The following is a description of a gene set: studied in species Homo sapiens An intracellular signaling cassette characterized by the NIK-dependent processing and activation of NF-kappaB. Begins with activation of the NF-kappaB-inducing kinase (NIK), which in turn phosphorylates and activates IkappaB kinase alpha (IKKalpha). IKKalpha phosphorylates the NF-kappa B2 protein (p100) leading to p100 processing and release of an active NF-kappaB (p52). The non-canonical NF-kappaB signaling pathway is generally activated by ligands of the TNF receptor superfamily, including lymphotoxin beta (LTB), CD40, OX40, RANK, TWEAK and B cell-activating factor (BAFF). Human Gene Set: GOBP_NON_CANONICAL_NF_KAPPAB_SIGNAL_TRANSDUCTION, and this is the list of marker genes: LGALS9, RIPK3, TRIM56, MKRN2, ZFP91, AMFR, CALR, CARD10, PHB2, SPI1, EZR, TAB2, RHOA, NLRC3, LIME1 (NCBI Gene Id 54923), MIR223, TCIM, BIRC3, REL, MIR149, COPS8, ZC3H12A, RELB, NFKB1, RELA, IL1B, MIR15B, NLRP12, NMI, IL23A, RBCK1, C1QTNF3, MIR9-1, AKIP1, PPM1A, RPS3, SASH1, BTRC, LAPTM5, HDAC7, TLR6 (toll like receptor 6), IL18R1, PTPN22, TNFSF11, NDUFC2 (NCBI Gene Id 4718), PYDC2, NOD2, BMP7, IFI35, LITAF, TREM2, NOD1, RIPK1, MIR27A, APP, IL18, TRIM6, HAVCR2, MIR508, LRRC19, TLR3, PYCARD, BIRC2, TAB3, TNFRSF11A, PTP4A3, TNFRSF10A, PRDX1, TRIM55, RC3H2, CARD14, AGO1, TRAF2, EDA, NFKBIA, DAB2IP, VCP, RTKN2, TERF2IP, NLRP3, TNFSF15, CCN3, CD27, PPM1B, MIR182, IL12B, BCL3, CCL19, TRIM26, TRIM40, PHB1, MIR27B, NFKB2, UACA, CPNE1, ZNF268, NR3C2, DDX3X, MAP3K14, CHUK, MIR766, CYLD, C1QTNF4, LETMD1, AGO3, MIR132, CD86, TNFSF14, EDAR, DLG1, TRIM15, GREM1, TRIM44 (tripartite motif containing 44), TRAF6, TRIP6, EIF2AK2, ACTN4 (actinin alpha 4), MIR29B1, NLRP2, RASSF2, HMGB1, ADISSP, RC3H1, CHI3L1, ADGRG3 (adhesion G protein-coupled receptor G3), MAP3K7, NOL3, TNF, TAB1, EDN1, FOXJ1, AGER, PDCD4, MIR21, TRIM60, SPHK1, ADIPOR1, BCL10, MIR204, TNFRSF10B